Given this list of marker genes Atp5pf, Atp2b2, Abce1, Srcap, Abcb4, Chd3, Macf1, Hfm1, Vps4a, Pex6, Mcm6, Atp11b, Ino80, Myo1e, Ercc6l, Fancm, Atp9a, Abca4, Kif15, Ddx3x, Atp9b (NCBI Gene Id 50771), Ddx18, Fignl2, Chd4, Abcc4, Ddx39a, Abcd3, Mcm8, Abca7, Myh7, Ddx55, Morc2b, Atp13a4, Kif19a, Atp2b1, Smpdl3a, Bcs1l, Vps4b (vacuolar protein sorting 4B), Smc6, Ercc2, Kif13b, Tap2, Morc3, Eif4a3, Tor2a, Atp5f1b, Ddx24, Dnah2, Kif27, Ddx54, Trap1, Xrcc5 (X-ray repair complementing defective repair in Chinese hamster cells 5), Alpl, Ide, Atp2c1, Atp1a3, Dhx58, Rfc1, Kif18b (NCBI Gene Id 70218), Kif22, Nav1, Kif13a, Ercc3, Ak6, Kif20a, Fignl1 (NCBI Gene Id 60530), Abcg3, Kif17, Rad17, Kif1a, Cct8, Ddx31, Slfn8, Mlh1, Hspa9, Kif12, Abcb9, Ddx1, Recql5, Hspa13, Rad51d, Ifih1, Ddx27, Abcd4, Psmc6, Abca8b, Abca5, Abcb11, Xrcc6, Atp6v1g1, Atp10a, Get3, G3bp1, Vcp, Eif4a2, Ddx50, Atp13a5, Chd9, Vwa8, Clpb, Hsp90aa1, Atad3a, Blm, Swsap1, Aqr (NCBI Gene Id 99376), Dnah8, Entpd7, Actb, Rtel1, Dhx30, Myo5a, Smc2, Msh2, Chd8, Atp6v1a, Myo3a, Rfc2, Rad51b, Abcf2, Tap1, Ola1, Nlrp1b, Chd6, Abcb1a, Abcf3, Polq, Atp5po, Dhx8, Atp8b2, Afg1l, Ddx42, Ddx47 (NCBI Gene Id 97288), Dqx1, Abcb1b, Abcc6, Nlrp10, Abcg8, Psmc1, Ddx11, Atp10d, Rad51, Abcc3, Ddx6, D1Pas1, Orc1, Rfc5, Atp1a2, Atp5f1c, Atrx, Mlh3, Carns1, Atp2b4, Atp8a2, Spast, Smarca5, Hspa14, Pms1 (PMS1 homolog 1, mismatch repair system component), Hsp90b1, Atp5f1a, Ythdc2, Ddx3y, Atp6v1g3, Ddx10, Atp11a, Atp13a3, Atp11c, Rad54l, Ddx20, Hspa1a, Psmc4, Rad50, Twnk, Ddx21, Dhx34, Entpd2, Ddx5, Atp1a1, Mtrex, Cftr, Lonp1, Abcc10, Abca6, Kif26a, Abca2, Tor3a, Chd5, Wrn, Rad54l2, Pif1, Rigi, Abca12, Kif20b, Kif14, Kifc1, Helb, Abcd2, Ercc6, Atp10b, Wrnip1, Ddx19a, Psmc2, Dhx36, Shoc1, Atp5pb, Morc4, Mov10l1, Recql4, Eif4a1, Pfn2, Chd7, Afg2a, Kif7, Dhx9, Dhx40, Tdrd12, Kif21a, Ruvbl1, Kif6, Atp7a, Atp2c2, Cct2, Chd1l, Iqca1l, Abca9, Atp5f1e, Tcp1, Mcm9, Atad2b, Ntpcr, Atp5f1d, Mcm3, Kif3b, Kif3a, Ighmbp2, Nubp1, Pex1, Chtf18, Hspa5, Atad1, Smchd1, Dnah3, Morc2a, Myo9b, Atp1a4, Kif28 (kinesin family member 28), Psmc5, Atp8b1 (ATPase, class I, type 8B, member 1, NCBI Gene Id 54670), Atp8b3, Atad2, Chd1, Abcc9, Mcm5, Abcd1, Smarcad1, Abcb6, Atp8b5, Afg3l2, Atp2a2, Cct7, Spg7, Trip13, Tor1b, Psmc3, Clpx, Afg3l1, Atad5, Atp2a3, Katna1, Abcb10, Dhx33, Katnal2, Atp4a (ATPase, H+/K+ exchanging, gastric, alpha polypeptide), Mcm4, Mcm7, Smc1a, Abca8a, Supv3l1, Cct6b, Myo5b, Cct6a, Abcb8, Dhx32, Upf1, Nlrp1a, Abcg2, Hsp90ab1, Mov10, Ddx4, Myo19, Kif5a, Kif23, Kifc2, Mcm2, Ddx49, Atf7ip, Lonp2, Kif1b, Ddx41, Iqca1, Rfc4, Abca1, Kif2b, Entpd1, Smarca4, Atp2a1, Brip1 (NCBI Gene Id 73108), Dnah5, Afg2b, Dnah12, Smc3, Atp8a1, Dmc1, Yme1l1, Fbh1, Kif5b, Ascc3, Kif2c, Dync2h1, Abcg5, Abcb5, Helz2, Hspa1l, Atp6v1g2, Hspa1b, Ddx39b, Abcc5, Kif18a, Kif19b, Hspa8, Orc4, 2310057M21Rik, Atp7b, Abcf1, Fign, Cct3, Tor4a, Ddx51, Dhx29, Ddx52, Nvl, Chd2, Srp54a, Abca13, Nav3, Rfc3, Ddx46, Smc4, Recql, Dhx57, Kif16b, Helq, Gpn1, Tdrd9, Kif2a, Kif1c, Abcc1, Slfn9, Kif9, Abca3, Cdc6, Atp13a2, Cct4, Nsf (NCBI Gene Id 18195), Ddx25, Snrnp200, Mmaa (methylmalonic aciduria (cobalamin deficiency) type A), Ddx17, Smc1b, Pms2, Tor1a, Ddx56, Dync1h1, Atp13a1, Ruvbl2, Dhx15, Kif21b, Myh8, Rnf213, Kif3c, Kif5c, Ddx28, Rhobtb3, Dna2 (NCBI Gene Id 327762), Ddx59, Abca17, Atp12a, Abcg1, Clu, Cct5, Kifc5b, Abcb7, Abcg4, Srpra, Nlrp3, Katnal1, Hspa2, Myh3, Abcc12, Abcc2, here is a description of the gene set: studied in species Mus musculus Catalysis of the reaction: ATP + H2O = ADP + H+ phosphate. ATP hydrolysis is used in some reactions as an energy source, for example to catalyze a reaction or drive transport against a concentration gradient. Mouse Gene Set: GOMF_ATP_HYDROLYSIS_ACTIVITY